Given this list of marker genes ASPM, ANKLE2, COPB2, CDK5RAP2, ARHGEF9, DPM1, TAF13, KIF14, PHC1 (NCBI Gene Id 283368), DHCR7, PYCR2, MCPH1, SLC35C1, TRAPPC14, WDR62, RNU4ATAC (RNA, U4atac small nuclear), CEP63, SARS1, CENPE, METTL5, CEP135, NUP37, SASS6, BRAF, VAC14, KNL1, FDXR, CDK6, RTTN, MCM7, NCAPD3, MBD5, WARS1, MFSD2A, FOXG1, CEP152, FIG4, TRAPPC10, STIL, CIT, here is a description of the gene set: species: Homo sapiens Human Gene Set: HP_HYPOPLASIA_OF_THE_FRONTAL_LOBES Underdevelopment of the frontal lobe of the cerebrum. Hypoplasia of the frontal lobes